Given this list of marker genes SEZ6L, MAP1B, KLHL20, CNIH2, GABBR1, PSEN1, SYT11 (NCBI Gene Id 92303), RTN4RL2, STRN, CNTN2, GPER1, SLC8A3, EPHB3, SLC3A2, MAPK8IP3, AKAP12 (NCBI Gene Id 9614), RPTOR, PHAX, SPG11, KCNN2, CCR2, IL6ST, EFNA2, RTN4R, KCND3, PTCHD1, CX3CL1, ATP1A2, RAC3, TAC1, TMEM266, SHISA6, GABRD, PIEZO2, CACNG2, ADCYAP1, OPN4, RGS7BP, NSMF, SLC38A7, ATP1A3, CRHR2, FZD3, DAB2IP, PDE9A, LDLR, RPS6, THY1, GRIA1, DIP2B, SORCS2, GLRB, RUFY3, TRAK1 (trafficking kinesin protein 1), FBXW11, PCDH8, OPRD1 (NCBI Gene Id 4985), PLK2, DYRK1A, PNOC, BPTF, UNC5A, NSG2, AKAP9, KIRREL1, IFT52, CAPN2, GLRX3, KATNB1, NPPA, ABI2, PTK2B, RTN4RL1, EPHB2, ARC, RELN, DHX36 (NCBI Gene Id 96337), ADORA1, PLEC, DBNL, CHRM1, SNAP25, OPRK1, OPHN1, CHRM4, KIFC2, TRIM3, TIAM2, TOP1, PPP1CA, ADAM11, ABHD17C, KIF3B, TRIM9, SYNGAP1 (NCBI Gene Id 8831), PI4K2A, HRH1, ROGDI, KCNA1, ELK1, NTRK2, SYNPO, MYOT, ADNP, CPLX1, GRIPAP1, RAC1, CACNA1A, EPHA7, ATP6AP2, CACNA1E, CRYAB, BGLAP, COBL, RGS7, ARHGEF7, FLNB, HRH3, STX4, CRHBP, STAU1, LRIT1, ARHGEF15, CACNG4, PLK3, BACE1, SLC17A8, AZIN2, ZDHHC12, CPNE5 (NCBI Gene Id 8901), AMIGO1, CHRM3, FLNA (filamin A), CSNK1E, ADCY8, GABRA5, PMM2, KCNN4, HIP1R (NCBI Gene Id 9026), SHISA9, VTI1A, CALB2, SRR (serine racemase), ADAM21, BRD1, SPTBN4, ADCY10, KLHL14, PDE1A, CLSTN2, TNN, SLC6A6, PTK7, HTR1F, TMPRSS5, KLHL1, HOMER1, PALS1, WDFY3, SMURF1, RACK1, ABITRAM (actin binding transcription modulator), MARK2, PTPRO, RAPGEF2, CPT1C, PUM2, GABRB1, ABHD17B, GNAI2, SMN1, TMEM100, TACR3, PURA, HTR2B (NCBI Gene Id 3357), TRPM5, BRINP1, TH, MUL1, MAP1S, ZC4H2, MAP6, LRP6, DRD1, KCNQ1, CTTN, NECAB2, HTR5A, LGI1, PDYN, CNKSR2, LZTS3, SLC18A2, HTR1B, FYN, RAB3IP, PRKCZ, KCNB2, TACR1, BRINP2, MYH10, PPFIA2, GRIN3A, TXNRD2, AKAP5, RAB17, UBXN2A, GRIA4, APP, PPP3CA, P2RY1, NMNAT3, PGRMC1, NEURL1 (neuralized E3 ubiquitin protein ligase 1), ASIC1, SLC12A2, ARHGAP32, RIC3, NDEL1, MAPK8, ASTN2, SYN1, MCRS1, KIF5C, ABHD12 (NCBI Gene Id 26090), CNNM1, CTTNBP2, CAMK2N1, SLC2A3, SYT4 (NCBI Gene Id 6860), TRAPPC4, DLG2, GABRE, GIT1, PTPRS, CASR, SLC1A3, HAP1, CREB3, JPH4, XRN1 (NCBI Gene Id 54464), DSCAM, FXR1, OSBP2, AGO2, NR1D1, HDAC6, MAPT, SEZ6L2, IFT57, NTF3, SLC6A2, IL1RAPL1 (NCBI Gene Id 4399), FAT3, APOE, BNIP3, MTMR2, P2RX2, GRM5, CAPRIN1, GFRA1, BSN, CHRM2, NRSN2, MAP1A, LRFN3, GABRA2, ITPR3, KCNIP2, NCF1, SLC1A4, HCN2, EFHC1, MME, RTN4, PDE1C (NCBI Gene Id 5137), RHOA, PPP1CC, FCHSD1, DCTN1, GNG3, CNGA3, DGKI, APBA2, RGS14, NAP1L4, PRKAR2B, SRCIN1, URI1, TANC1, BMPR1A, GABRG2, KLHL24, FCGR2B, SORBS2, CYP17A1, UCN, GABRB3, BDNF, DAGLA, HTR6, ITGA8, LAMA2, CACNG3, OLFM1, GRIN1, AVP, MT3, LPAR1, FEZ1, NEGR1, INPP5J, SMN2, ZMYND8, SLC6A3, RARA, SAMD4A, FBXO31, EIF4A3 (eukaryotic translation initiation factor 4A3), ASTN1, WASF1, CAMK2A, RGS8, GNAO1, FLRT1, DRD2, MAF1, ADCY2, TTLL7, LZTS1, MLPH, WDR47, TMEM151A, SHANK2, TGFB1, AGFG1, DLG4, ITGB1, ENDOG, CDK5, UHMK1, TANC2, DNAJB1, HPCA, CNR2, RAB8A, RAB27A, DCP1A, EPHB6, L1CAM, APOD, TRPM4 (transient receptor potential cation channel subfamily M member 4), HSP90AB1 (heat shock protein 90 alpha family class B member 1), SEZ6, ITPKA, CYBA, NF1, EFNB2, LYNX1, LMTK3, SLC12A5, LRRK2, RPL28, CTNND2, SLC8A2, FGF13, SRGAP2, SLC6A1, DNER, CHRNA7, NLGN4X (NCBI Gene Id 64642), SKOR1, UBB, ERCC8, SST, PRKAA2, SHISA8, PTCH1, CDK5R1, APBA1, GABRG3, PREX1, PMM1, FZD4, TRPC5, GSK3A, ARF4, GRIA2, DTNBP1, PRNP, APBA3, CACNA1F, CRMP1, CASP3, CACNG8, ADCY9, RAP1GAP, CRIPT, CASC3, SMO, MBP, HRH2, TMEM185A, TMPRSS3, PTPRF, CLCN2, RPH3A, WHRN, ZPR1, GABRG1, S100B, ZFYVE27, WFS1 (NCBI Gene Id 94141), GIPC1, CYGB, MAP2, GRM6, TSC22D4 (TSC22 domain family member 4), ADORA2A, EVX1, DRP2, G3BP1, N4BP3, TMEM108, WASHC5, EPM2A, FUBP3, ABHD17A, SLC8A1, PHAF1, NSG1, FBXO2, GRM3, TRPV1, RRM1, GABRA3, ATP13A2, SIAH2, ITGA4 (integrin subunit alpha 4), NIN, DIP2A, PRKCG (protein kinase C gamma), ACTN2, TENM2, LUZP1, KIF5B, HNRNPAB, PPP5C, RBM8A, NLGN2, TBX21, ENC1, SACS, DVL1, PTEN, ABI3, AMFR, PPP1R9A, MAST1, FLOT2, CHRM5, MPL, KCNC4, GHR, MPP2, DDN, TNF, HTR2A, KCNN1, ATXN1L, CACNG7, P2RX7, HTR2C, SARM1, ZWINT (ZW10 interacting kinetochore protein), TUBB3, GRM1, LRRC4, SRSF10, ADRA2A, HNRNPU, MINK1, OPRM1, PPP2R1A, PRRT2, KCNA2, MAGEE1, BAG2, ARHGAP33, GABRA1, SLC4A10 (NCBI Gene Id 57282), DRD4, C4A, PSD, SNCAIP, KCNC1 (NCBI Gene Id 3746), RCVRN (NCBI Gene Id 5957), NRDC, SIPA1L1, SLC24A1, POLR2M, HCN3, CIB1, NPFF, ADAM10, VPS16, KCNC3, PPP1R9B, P2RX6, PAFAH1B1, PENK, GNB5, STX3, CD22, KCNIP1, NRGN, SHTN1, GNAT1, ARFGEF2, SPTBN2, KIFAP3, ARHGAP44, SLC25A27, PPT1 (palmitoyl-protein thioesterase 1), EEF2K, STRN4, SERPINF1, CFL1, SFPQ, KIF17, DBN1, KCNK9, ABHD13, PPP1R1B, ASIC2, KIRREL3 (kirre like nephrin family adhesion molecule 3), ADCY4, SLC38A1, KIF1B, EPHA3, TAOK2, GPM6A, LRP8, RNF112, SCN11A, HMCN2, TPBG, CPEB4, KCND2, GSK3B, KPNA1, UCHL1, GIGYF2, CLU, IGF2BP1, DNM3, ACAD9, EPHA8, GRIN3B, NTRK1, DTNB, MARK3, MAP2K1, KIF21B (kinesin family member 21B), ELAVL4, NDN, HDAC1, KIF1C, TP63, BIN1, MYO1D, OPA1, BAIAP2, CADM2, SEMA4F, KCNK1, CHRNA4, PLXDC1, PICALM, SNCA, GRM7, HOMER2, MAGOHB, GPHN, KCNK2, ATOH7, HCFC1, RAB5A, JAM2, ERMN, CACNA1B, GNRH1, NRSN1, NRXN1, BECN1, ATP7A, ATCAY, ERO1A, CALCA, LRP2, PDE4B, PSD2, GNG13, RBM3, MT-ND1, MIR107, VSTM5, RABGEF1, HTR1D, NECTIN1, CACNA1C, NTSR1, KCNA4, HPN, KCNJ2, SLC30A1, SORL1, ITSN1, GNA12, IFT20, SCGN, MARK4, HTT, SEPTIN14, CD2AP, DPYSL5, ELOVL5, NSF, PDLIM4, KIF1A, HOMER3 (homer scaffold protein 3), SEPTIN11, TUBB4A, NGDN, CD3E, USH2A, LRIT3, KIF5A, PAK1, SIRT2, UNC5C, SCN1A, GABRB2, SOD1 (NCBI Gene Id 6647), TRPM2, SLITRK2, TPX2, PYCARD, SLC4A8, PTBP2, VPS13A, ANK3, ATXN10, S100A5, ATF4, FRMD7, SHANK1, KCND1, KREMEN1, COMT, IAPP, ALS2, FKBP4, BMPR2, NDFIP1, RTN1, MTOR, C4B, SAMD14, MAPK8IP2 (mitogen-activated protein kinase 8 interacting protein 2), MYL7, TRAK2, STMN2, GRID1, MDGA1, EPHA4, EPHA10, SLC9A5, AURKA, GLRA3, CPLX2, PRKN, LHFPL4 (NCBI Gene Id 375323), GRIN2A, TTBK1, PPFIA1, GRID2, KNCN, GLRX5, EPHA6, NECTIN3, ADGRB1, GPR179, IGSF9, BMPR1B, GRIA3, GPR37, ITGA1, NPY, GRIK2, LMTK2, SYNDIG1, SRD5A1, KCNH1, MYO10, RANGAP1, PALM, SCN1B, SLC1A1, GRIP1, MAX, LRP4, CX3CR1, STAT1 (signal transducer and activator of transcription 1, NCBI Gene Id 6772), FRMPD4, GAP43, GAL, SRD5A2, TPGS1, SLC32A1, GNAZ, HTR1A, CLSTN3, INSR, SNX14, GHRH, TMEM50A, ADORA3, UPF3B, GLRA1, SEPTIN4, EPHB1, INHA, PTPRN, GCHFR, NEUROG1, CDC42, PALMD, STRN3 (striatin 3), NDUFS7, SLC22A3, ALCAM (NCBI Gene Id 214), CNIH3, BCR, KNDC1, ZC3H14, ANKS1B, NAPEPLD, GRIN2B, LAMP5, ABR, INPP5F, HTR1E, VPS35, ZNF385A, CPEB3, YKT6, CD40, ANG, APOB, RGS12, PDE1B, SLC5A7, NGFR, CRH (NCBI Gene Id 1392), SGCE, PRPH, LYPD6, TMEM222 (NCBI Gene Id 84065), MPDZ, CHRNA3, ASS1, ENO2, CHL1, ASCL1, SHANK3 (NCBI Gene Id 85358), DMWD, HTR4, RIT2, KIF21A, FARP1, EPHA5, MAPK8IP1, AGRP, ABL1, KCNC2, BRINP3, RIN3, CYBB, CALB1, NTF4, TMC7, SYT5, C9orf72, HTR7 (NCBI Gene Id 3363), GRIK3, GABRA4, ZDHHC5, STAU2, ATP2B2, CNTF, HRH4, SOS1, PRR7, PRSS12, VTI1B, SNCG, NGF, CHRNA10, SYAP1, SNCB, GRM2, HSP90AA1, HCN4 (hyperpolarization activated cyclic nucleotide gated potassium channel 4), CPNE6, KCNB1, OMP, SERPINI1, FMR1, NCDN, KCNE3, DOCK10, TGFB2, SLC38A2, GNB3, SHISA7, NUMA1, NLGN1, INPP5A, ZNF804A, KCNN3, MAGI2, CDKL5, USP33, CPEB1, CNTNAP2, GDI1 (NCBI Gene Id 2664), CYP46A1, NCS1, FZD5, HCN1, CD200, PJVK, MARK1, PRKAA1, CAD, ELFN1, GOPC, GABRA6, NOS1 (NCBI Gene Id 4842), here is a description of the gene set: studied in species Homo sapiens Human Gene Set: GOCC_SOMATODENDRITIC_COMPARTMENT The region of a neuron that includes the cell body (cell soma) and dendrite(s), but excludes the axon.